The following is a description of a gene set: Mouse Gene Set: GOBP_REGULATION_OF_MICROTUBULE_BINDING Any process that modulates the frequency, rate or extent of microtubule binding. studied in species Mus musculus, and this is the list of marker genes: Ttbk2, Mapre1, Gas8, Mapre3, Abl1